The following is a description of a gene set: studied in species Homo sapiens Human Gene Set: GOBP_CELLULAR_RESPONSE_TO_COLD Any process that results in a change in state or activity of a cell (in terms of movement, secretion, enzyme production, gene expression, etc.) as a result of a cold stimulus, a temperature stimulus below the optimal temperature for that organism., and this is the list of marker genes: FOXO1, DNAJC3, EIF2AK4, PLIN1, SAXO1, SCN11A, UCP1, NFE2L1, TRPA1, PRKACA, EIF2AK3 (NCBI Gene Id 9451), RNF34, NFKBIA, SLC9A1 (solute carrier family 9 member A1), CIDEA (NCBI Gene Id 1149)